The following is a description of a gene set: Mouse Gene Set: ZFP709_TARGET_GENES from publication Yevshin I, Sharipov R, Kolmykov S, Kondrakhin Y, Kolpakov F (PMID 30445619) species: Mus musculus, and this is the list of marker genes: Glis3, Doc2g, Srp72, Gm14175, Grm1, Hsph1, Hspe1, Ltbp1, Hsp90ab1, Hsp90aa1 (heat shock protein 90, alpha (cytosolic), class A member 1), 4933408N05Rik, Gm25184, Gm26070, Sema4d, Ubxn1, Gal3st1, 4921513I03Rik, Dsc1, Cygb, Mir3085, Gys2, Cbx3, Xpnpep3, Mtfr1, Rph3a, Adig, Copg2, Carhsp1, Gfm1, Rsrp1, Gm13213, Thpo, Hhip, Habp2, Eeig1, Ssc4d, Agpat2, Akirin2, Pdcd6ip, Tmem61, Pzp, Gm24665, Cib1, Nav2, Rcor3, Fam241b, Dhps (deoxyhypusine synthase), Gm13842, Xrn1, Capn10, Hspd1, Ptges3, Gm12464, Oas2, Kank3, Nr6a1os, Casp8, Meg3, Gm26343, Mir7074, Mrpl18, Hspa8, Gm14210, Flvcr1, Gm8213, Slc38a8, Smg5, Mir1306 (microRNA 1306), Atp8b3, Gm26049 (predicted gene, 26049), 1700022A21Rik, Pdia3, Fbxo42, Rps27a-ps3, Znrf4, Agap3, Chordc1, Tigd4, 1110028F18Rik, Iho1, Uqcrc2, Cdkn1a, 1700019D03Rik, Cradd, Nuak2, Lrriq1, Dync1h1, Atp8b4, Cxcr5, Dnajb2, Dbn1, Timm13, Rpl9-ps4, Gm11292, Ttc24, Atp6v0d1, Tpt1, Mdk, Abcc3, Rhot1, Lztr1, Rnf20, Gtf2i, Gm4035, Gm23054, Ralgps2, Fbxl22, Dnaja1, Sqstm1, Uba2, Dhx9, Tatdn2, Gm28874, Ddx23, Lce3c, Gm6096, Setx, Gm15266 (predicted gene 15266), Tcp1, Pde4d, Zfp512b, Cep164, Jakmip1, St14, Gamt, Gpr84 (NCBI Gene Id 80910), Gm24068, Gna11, Gm25489 (NCBI Gene Id 115489636), Tdrd9, Mxra8, Catsper2, Gins2, Hnrnpa2b1, Gm14095, Wsb1, Il4, H2-M5, Gm16096, Fkbp4, Fhip2b, Gm12828, Gm10069, Sp1, St13, Tpd52l2, Msh3, Rdm1, Gm19705, Tbl3, Rnf125, Gm24615, Maf, Ninj2 (NCBI Gene Id 29862), Gm4285, Adarb1, Tal1, Klf1, Cnbd2, Banp, Mir3618, Evl, Gm22972, Echs1, Gm12654, Dgcr8, Gm25608, Ptrh2, Klhl22, Fn1, Or1e22, Pask, Ube2h, Mir207, Nr6a1, Pdxdc1, Aurka, Aste1, 2900052L18Rik, Kmt2d, Dkkl1, 2810407A14Rik, Crem, Tra2a, Cpsf4